The following is a description of a gene set: Human Gene Set: YANAGIHARA_ESX1_TARGETS Gain-of-function mutation of the K-ras gene is one of the most common genetic changes in human tumors. In tumors carrying K-ras mutation, the presence of oncogenic K-Ras is necessary for maintenance of the transformed phenotype. ESXR1 is a human paired-like homeodomain-containing protein expressed primarily in the testis. In cells, the 65-kDa full-length ESXR1 protein is proteolytically processed into an N-terminal 45-kDa fragment containing the homeodomain, which localizes exclusively within the nucleus, and a C-terminal 20-kDa fragment consisting of a proline-rich repeat region, which is located in the cytoplasm. In this work, we demonstrated that the N-terminal ESXR1 fragment specifically recognizes the TAATNNNATTA P3 consensus sequence for the paired-like homeodomain and functions as a sequence-specific transcriptional repressor. We also showed that the N-terminal ESXR1 fragment binds to the TAATGTTATTA sequence present within the first intron of the human K-ras gene and inhibits its expression at both mRNA and protein levels. Ectopic expression of the N-terminal ESXR1 fragment in human carcinoma cells that carry mutated K-ras reduces the level of K-Ras and thereby inhibits the tumor cell proliferation. Identification of ESXR1 as a transcriptional repressor of K-ras has an important implication for the development of cancer therapy that inhibits oncogenic K-Ras expression. species: Homo sapiens Genes down-regulated in U2-OS Tet-On cells (osteosarcoma) after induction of ESX1 expression. from publication Yanagihara M, Ishikawa S, Naito M, Nakajima J, Aburatani H, Hatakeyama M (PMID 15897875), and this is the list of marker genes: ACTR2, SS18, MAP4K5, NEXN, ARHGAP29, RHOBTB3, DYNC2H1, PIP5K1A, PCLO, GNS, SRSF11, BDNF-AS, CRTAP, TGFB2, CYP24A1, IL18, INPP4B, TPR, MARCKS, MCF2, HMGCS1, TAF15, DAB2, RASAL2, KRAS, CLCN4, IL6ST, SNX13, BMP5